Given this list of marker genes Maob, Npy, Pebp1, Paox, Vps35, Gpr37, Abat, Hprt1, Epas1, Park7, here is a description of the gene set: species: Mus musculus Any process that activates or increases the frequency, rate or extent of the chemical reactions and pathways involving amines. Mouse Gene Set: GOBP_POSITIVE_REGULATION_OF_AMINE_METABOLIC_PROCESS